Given this list of marker genes Kpna6, Sinhcaf (NCBI Gene Id 56306), Pcdh19, Kdm2a, Prkag2, Srrm4, Ubr5, Ank1, Ydjc, Rab1a, Btrc, Jade3, Zfp846 (zinc finger protein 846), Map1a, Tnrc6a, Fkbp1b, Peak1, Ctnnbip1, AI467606, Aopep, Ms4a6d, St8sia5, Clcn3, Adcy7, Tpt1, Slc12a6, Extl3, Dnmt3a, C2cd4c, Ankrd33b, Lyar, Mapk10, Rab11fip4, Tpp1, Nhsl3, Psmc6, Camta1, Arl14ep, Scn2b, Zfand5, Susd6, Gabrq (NCBI Gene Id 57249), Usp26, Dhcr24, Nedd4l, Sort1, Maco1, Pheta1, Tbk1, Ngfr, Tm7sf3 (NCBI Gene Id 67623), Patl1, Cacna2d1, Ccdc92b, Usp3, Fgf7, Txnrd3, Cfap97d1 (CFAP97 domain containing 1), Tnfrsf21, Khnyn, Eml6, Slc24a3, Pdcd4, Fam135a, Pkd2, Ngef, Tirap, Gpbp1l1, Ccnq, Mtss2, Tfeb, Grm5, Ago1, Sacm1l, Sh3pxd2a, Pde4c, Lrrc59, Arl5b, Ago4, Cdh6, Gucy1a2 (guanylate cyclase 1, soluble, alpha 2, NCBI Gene Id 70710), Pxylp1, Itgb1bp1, Megf9, Slk, Esp3, Unc13c, Kcnq5, Lypd1, Septin9, Parn, Plcb1, Rab8b, Vps25, Rnf111, Taf5l, Tuba4a (NCBI Gene Id 22145), Lgr6, Zfp574, Eif5b (NCBI Gene Id 226982), Kcnk2, Srpk1, Cnksr2, Runx2, Onecut2, Ice1 (interactor of little elongation complex ELL subunit 1), Cited2, Mxd1, Fam76a, Sv2b, Rfc5 (replication factor C (activator 1) 5), Mrpl58, Paip1, Clgn, Trim31, D5Ertd579e, Grm7, Ccn5 (cellular communication network factor 5), Pitpnm3, Il21r, Aak1, Dcaf10, Adam23, Tctn1, Sec24a, Lgr4, Lamc1, here is a description of the gene set: species: Mus musculus Genes predicted to be targets of miRBase v22 microRNA mmu_miR_6954_3p in miRDB v6.0 with MirTarget v4 prediction scores > 80 (high confidence targets). Mouse Gene Set: MIR_6954_3P from publication Chen Y, Wang X (PMID 31504780)